Given this list of marker genes ZNF740, CCDC146, WASHC2A, ZFP1, ZNF264, MATN4, RTF1, IBTK, CHIC2, SLC25A40, SMC5, MORC3, TAF8, CNTD1, CYP2D6, MDP1, TMEM86B, MPP4, AMN1, VPS37C, CCAR1, POU6F1, C6orf62, EARS2, KIAA1217, PARP14, TMOD4, PRXL2C, FAM199X, PDPK1, UPF3B, SACS, TMEM268, CIR1, SFT2D1, VWA2, PHF23, SPATA31F1, MAGI2, RPL18A, ATP2A3, XRCC4, CIC, B2M, ARHGEF1, ANGPTL1, LGALS8, DLX2, CERS6, PTPN22, ITCH, ATP6AP2, TM4SF20, PGS1, GZMK, RAPGEF1, MALAT1, ARHGAP9, ESF1, REXO4, DRAM2, MACC1, KBTBD2, CCDC66, TMEM245, STX1A, ZC3H15, BTBD1, MTSS1, ATP8B3, AP4S1, FUT8, DAND5, MSRA, ADAMTSL4, NAB1, DUBR, TP53INP1, TAX1BP1, SYAP1, SPNS1, CIAO3, NEMF, MPLKIP, IREB2, CCDC68, HES6, PCGF1, MKNK1 (MAPK interacting serine/threonine kinase 1), ST3GAL6, CLIC3, CASP8AP2, B3GNT7, MSN, DAAM1, HNRNPA3, ECM1, RTL8C, IST1, ETS1, ANGEL2, CASP8, FXR1, SPRTN, CCDC39, IGBP1 (immunoglobulin binding protein 1), GIGYF2, TSKS, TPRA1, TERF2, CACUL1, CPEB2, ZNF467, ANKRD10, C2orf68, DGKE, PIK3R1, ELOVL5, CTSE, OSBPL8, TESC, PARP8, FHIP2A, MSRB2, KIZ, WIPF2, DPM1, RNF123, HNRNPH1, TSPAN13, COA4, CGGBP1, MTFR1L, ATOH7, G0S2, RAB2A, SUSD6, FAM193B, TCF12, ACAA1, DNASE1L2, NISCH, CELSR1, MED13L (mediator complex subunit 13L), CENPJ, RNASEL, LRRC75B, MAGI3, PCNX3, ANKRD26, BBOF1, WTAP, ING5, B3GNTL1, ESR1, ELF4, ZNF708, NFE2L2, CD48, RNASE6, ARL5A, GUCD1, VPS9D1, RPS3, TOR1AIP1, SNRNP48, ENO4, CAPN15, MTFMT, ANTXR2, AKIRIN1, SNX2, CLCN7, RYR3, TRAPPC8, PTPN12, AP3D1, TERF1, SFMBT2, RAB10, HEXA, SNAPC1, WDR44, RPS6KB1, ZBTB11, KDM5B, KCTD2, PRMT9, CHORDC1, GIN1, FAM163B, PLEKHS1, ARPC5, TRAPPC6B, RMC1, RPL38, DYDC2, PRICKLE2, ENTPD6, here is a description of the gene set: from publication Wei G, Wei L, Zhu J, Zang C, Hu-Li J, Yao Z, Cui K, Kanno Y, Roh TY, Watford WT, Schones DE, Peng W, Sun HW, Paul WE, O'Shea JJ, Zhao K (PMID 19144320) Genes up-regulated in comparison of naive CD4 T cells versus induced regulatory T cell (Treg). Human Gene Set: GSE14308_NAIVE_CD4_TCELL_VS_INDUCED_TREG_UP Multipotential naïve CD4+ T cells differentiate into distinct lineages including T helper 1 (Th1), Th2, Th17, and inducible T regulatory (iTreg) cells. The remarkable diversity of CD4+ T cells begs the question whether the observed changes reflect terminal differentiation with heritable epigenetic modifications or plasticity in T cell responses. We generated genome-wide histone H3 lysine 4 (H3K4) and lysine 27 (H3K27) trimethylation maps in naïve, Th1, Th2, Th17, iTreg, and natural (n)Treg cells. We found that although modifications of signature cytokine genes (Ifng, Il4, and Il17) partially conform to the expectation of lineage commitment, critical transcription factors such as Tbx21 exhibit a broad spectrum of epigenetic states, consistent with our demonstration of T-bet and IFN-gamma induction in nTreg cells. Our data suggest an epigenetic mechanism underlying the specificity and plasticity of effector and regulatory T cells and also provide a framework for understanding complexity of CD4+ T helper cell differentiation. studied in species Homo sapiens